The following is a description of a gene set: Human Gene Set: GOBP_GROWTH studied in species Homo sapiens The increase in size or mass of an entire organism, a part of an organism or a cell., and this is the list of marker genes: MATN1, ZNF830, OTOA (NCBI Gene Id 146183), TAF9B, PLEKHA1, TSC22D4, RMI1, FGFR2, STK4, SEMA5B, GLI2, PTCH1, FLRT3, GAS2, ULK2, UBE3A, TAOK2, SH3BP4, EIF4G1, ASPM, CDK1, KPNA1, SOCS2, MYF6, CYP27B1, CDKN1B, GOLGA4, LEPR, EPM2A, FTO, MIR17HG, BMPR2, NRN1L, RBBP6 (RB binding protein 6, ubiquitin ligase), MMP14, HDGFL2, MIR199A1, H3-3B, CDC42, EZR, BLTP1, IL17RB, SGK1, GINS4, MFSD8, AURKA, SPOCK1, RPS6KA3, FGF8, FOXC2, DIO3, COMP, ABL1, PTPN12, HNF1B, WNT3A, RGS2, DVL1, IFT80, GPD2, SOX15, HSF1 (heat shock transcription factor 1), ECM1, BCAR1, GDF2, TTL, GPX4, CYBA, TFRC, IGFBP1, COL27A1, NDRG3, EDN2 (NCBI Gene Id 1907), SPP1, CD81, BBS4, PTPRJ, MIR548C, SGPL1, GALNT3, DDR2, RASGRP2, KDF1, ITSN2, SERPINE2 (serpin family E member 2), BTG1, CHPT1, EZH2, PSRC1, AGT, TSKU, OLFM1, ADCY10, CDK5, IGFBP3, ACVR2B, KMT2D, EMX1 (NCBI Gene Id 2016), G6PD, JADE2 (jade family PHD finger 2), CLSTN1 (calsyntenin 1), CIB1, PPP2R1A, BARHL2, MIR24-1, RNF157, HOXB13, LATS2, ZFPM2, DACT3, SYT17, MLST8, PAX7, PSAP, PLXNA4, WNT10B, AFG3L2, OSGIN2, AGRN, CDKL5, INSR, SOX17, DDX3X, LARGE1, PPP2R3A, NTRK3, PYGO2, SPHK1 (NCBI Gene Id 8877), INO80, CER1, ETNK2, ARHGEF11, KLHL22, ITGB1, BBS2, S1PR1, CDHR2, APOA5, SERP1, ESR2, RACK1, GINS3, SLC1A2, P2RX5, MAPKAP1, AKT1, ALCAM, PSMD10, COBL, SEMA7A, MAP2, MT1B, WT1, WNT2 (NCBI Gene Id 7472), CDA, HSPA1A, PPP1R13L, SLC23A2, XIRP1, LIMK1, WNT3, SOX9, EPHX2, ADRB2, SPAAR, HEY2, RGMA, CD2AP, HSPA1B, NRP2, SMAD1, COL14A1, KLK6, FKRP, HESX1, PAK5, TRPV2, ADM, CRYAB, LAMB2, LIN7A, MIR509-1, LGR6, PIM1, NDRG4, YBX3, MAPT, KIF26B, CACNG7, PPM1F, SFRP2, CHD7, RAI1, WNT7A, GHRL, SMPD3, NDN, GDF15, IGF1 (NCBI Gene Id 3479), PPARD, RSPO2, CAV3, KAT7, SELENON, MYL2, CHRNA1, MAP3K13, BIN3, TOMM70, MIR25, DCSTAMP, ADRA1A, HTRA2, HBEGF, SUPV3L1, SBDS, ACTN3, STRA6, RAD51B, MAEL, ING1, NUBP1 (NUBP iron-sulfur cluster assembly factor 1, cytosolic), ISLR2, PTPN11, RPS6KA1, GH1, FGF20, GNAT2, CCL11, CHEK1, MAPK11, WASF1, CDKN2AIP (CDKN2A interacting protein), ATRN, NTN1, WFS1, BCL2L11, MT1E, ING4, TM4SF4, GHRHR, TMEM38B, PTK6, S100A8, L1CAM, NLGN3, IGF2, NDUFS6, MTOR, TBCE, CTC1, KIAA0319, PALB2, PRSS2, TRIM32, FGF2, PLXNA1, VPS54, POSTN, USP9X, DNM2, SEMA6C, SLITRK6, RPTOR, NCBP1, BMPR1B, PLAG1, POU4F3, EP300, MAG, STC2, PPP1R9B, PAPPA2, NCAPG2, SOX10, BRINP2, HDAC3, SMARCA2, PRLH, SDCBP, GATA3, ITCH, N6AMT1, SLITRK1, CCM2, MIR590, NPR1, EGFR, PRKN, CSNK2A3 (casein kinase 2 alpha 3), ATG16L1, MIR204, ATRX (NCBI Gene Id 6475), PTN, PAK1, ZC3H12D, CHRND, STAT5A, PTGFRN, ROS1, CRK, TNR, PRKAR1A, HRG (histidine rich glycoprotein), CRYAA, SMAD2, PSAPL1, SMAD7, HOXA11, ARMC12 (NCBI Gene Id 221481), RERG, TRPC5, HOXA5, TFCP2L1, BASP1, MYCBP2, MESP1, DDX49, IGFBP7, GLI1, IER3IP1, BRCA2, MT3, PRLR, EREG, FLRT1, EIF4H, PPP3CB, PROX1, MUL1, WWTR1, JADE1, BCL6, LIN7C, COX10, ZFY, MSTN, RIMS2, FXN, CFL1, MED1, APBA1, WFDC1, SORBS2, GAMT, FOXC1, AGTR2 (angiotensin II receptor type 2), YAP1, CEACAM1, SLC6A3, SPAG6, GPX1, EVC, TNFAIP6, MACF1, NIN, SLC4A10 (solute carrier family 4 member 10), PML, SLC12A5, RDH10, DUSP10, PLAC8, CSF1, CD38, MDK, SLC44A4, TMPRSS4, WWC2, TLL2, HEG1, OPA3, MT1G, SLIT2, MMP13, LRP12, RARB, NRN1, PLS1, MT1H, SIX1 (NCBI Gene Id 6495), STC1, FBLN5, ENO1, SMURF1, NPPC, SEMA3F, SLC9A1, DNPH1, DCC, GPR149 (NCBI Gene Id 344758), SPTBN2, CXCL12, TMEM182, NKX6-1, TFAP2C (transcription factor AP-2 gamma), KAT2A, MYMX, BCL2, SPHK2, GNAS, GPR21, ATM, CGRRF1, LTBP4, MYOD1 (NCBI Gene Id 4654), UNC13A, ADPRHL1, C8orf44-SGK3, PAK6, GHR, CCNB1, WNT5A, IST1, MTM1 (myotubularin 1), TEAD1, ST7L, GNG4, RUFY3, FSHR, CGA, SELENOP (NCBI Gene Id 6414), AVP, COA5, FGF1, PRPF19, MIR222, SMARCA4, GRHL2, BCL9, MT1F, CTDP1, EIF4G2, KCNJ8, RIMS1, MT1M, CDKN2C, FKBP8, IGFBP4, VGLL4, PI16 (peptidase inhibitor 16), LAMTOR1, MSX2, INHBA, DMBX1, S100A9, CPNE9, PLCB1, SAV1, EDN1, NPPB, CCNB2, GDF5, ADNP, ZNF639, PHLDA2, ADARB1, SEMA6D (semaphorin 6D), ACACB, SYT3, PPP3CA, H3-5, POC1A, MYH6, SMAD4, HYAL2, ACVR1B, LLGL2, FGF10, CDKN2D, SYT1, TARBP2, MCUB, SPRY1, PPIB, TP73, LHX2, GJE1, SLIT3, PARP2, SKI, MKKS, ENPP1, IL2, FGF7, APP, C9orf72, NINJ1, MT1X, RAB33B, RARG, WDTC1, FSTL4, P3H1, TMEM97, ZFP36L1, OGFR, SESN2, EDNRA, KCNK2, DIPK2A, MIR23A, COL3A1, BNC2, VCL, TGFBR3, TBX2, PRMT2, DRD2, KRAS, SPART, PUM2, TAF8, MAP1B, ATP8A2, NAIF1 (nuclear apoptosis inducing factor 1), APBA2, ATF2, NPPA, B4GALNT2, PKDCC, PTEN, CELA1, PTPRS, ANAPC2, TGFB1, MAPK14, FZD9, NR5A2, TWF2, SEMA4F, ERCC6, VPS13A (vacuolar protein sorting 13 homolog A), XRCC2, ADRB1, EFNA5, MINAR1, MIR195, LGMN, KRT17, TRIM46, LPAR3, SEMA3G, EHMT2, BRINP3, ADIPOR1, ZMPSTE24, LMX1A, SFN, ST8SIA2, CXCL16, TNC, TSPYL2, COL6A1, PELO, EAF2, TGFB2, SFRP1, SALL4, CTTN, SIX3, CYP19A1, CCAR2, PRDM11, ARHGAP4, MELTF, ADAM15, CLIC4, ARIH2, MTPN, PDLIM5, CFLAR, AGR2, PPT1, NRG3, RBP4, PEX5, WNT11 (NCBI Gene Id 7481), GAREM1, TAF10, CDKL3, GPC3, TTC8, NANOS1, LZTS2 (NCBI Gene Id 84445), TMEM108 (transmembrane protein 108), SGK2, CPQ, MT2A, KDM2B, PRKCQ, CREB1, FAM107A, SOD1, MAD2L2, STK11, TMED2, GUCA2B, ADRB3, ZMIZ1, CLASP2, OSGIN1, BAP1, LIN7B, CSNK2A1, RASAL1, CPNE5, DUSP6, GMNC, AVPR1A, URI1, IL7, AAAS, PIK3CA, CD9, SPTBN4, BDNF, RB1, LEP, JARID2, NKX2-5, KLF5, MIR1-1, IQGAP1, CDH4, SRF, FHL1, TBX5, CAMK2D, LGI1, CDK11B (NCBI Gene Id 984), XBP1, PLXNA3, KIF14, BCL11A, PAFAH1B1, F2, ACVR1C, DAG1, ULK1, THBS3, TBL1XR1, SEMA3A, NRP1, TGFBR2, OSTN, GLI3 (GLI family zinc finger 3), RTF1, ODAD3 (outer dynein arm docking complex subunit 3), CPNE1, AR, ESR1, TRIM28, EIF2AK4, NPR2, EXT1, PTK7, CRLF3, EBAG9, SEMA5A, APOE, MEG3, GHSR, SMO, SALL1, AGTR1, PPARA, MEIS1, MAP2K5, CDKN1C, LRP4, RARA, ACSL4 (acyl-CoA synthetase long chain family member 4), WNT7B, TRIM40, NME6, POR, CYFIP1, SERTAD3, NGF, CTNNB1, SYT2, MED12, ZEB2, TSG101, EI24, ARMC10, RTN4, MIR19A, INS, RAPH1, MIR29B1, MBD5 (methyl-CpG binding domain protein 5), ALKBH1, NRG1, KIF26A, STK3, RNF6, GPAT4, FBP1, SERTAD2, COLQ, PTCH2, DCUN1D5, DNAAF3, CDKN2A, GSK3B, AMH, MUSK, IMPACT, SEMA4D, ARID2, EGLN2, SPAG9, VIL1, HNF4A, IHH, SYT14P1, CAPN3, LAMTOR2 (NCBI Gene Id 94954), RYK, LLPH, ALOX15B, EXOSC9 (exosome component 9), KAZALD1, TEC, FOXL2, VPS13B, HYAL1, HMGA2, SIX4, MIR200B, SOX2, SCNN1B, RTN4R, FOXP1, GDI1, DAB2, SPRY2, NOG, CDC73, GATA6, WDR11 (NCBI Gene Id 79207), BRCA1, GDF9, FGFR3, ZPR1, LATS1, ARX, EYS, COPS2, EDN3, HDAC6, SIN3A, SLC39A12, SYT4, RAB21, CCN3, CAPRIN2, POU3F2, PABIR1, PRR5, IFRD1, NEDD4L, HOXD13 (NCBI Gene Id 7859), UBTFL1, DCLK1 (NCBI Gene Id 9201), UCN, MUC12, APOD, NKD1, BDKRB1, MT1A, NLGN4X, PPP2CA, GHRH, COMT, NBN, FGF13, FES, SGK3, ARID5B, TNFRSF12A, EPPK1, RUNX1, CYFIP2, STIL, RAG2 (recombination activating 2), MYOZ1, CCDC85B, JADE3, RASAL2, BCL2L1, BNIPL, CLDN18 (NCBI Gene Id 51208), G6PC1, SH3GL2, GIGYF2, SHH, GATA4, SOS1, NOTCH2, GNAT1, MYOCD, YY1, ITGA4, CLSTN3, ADAM17, EN1, NOTCH1, RBPJ, IL9, TNN, ACVRL1, HLX, CACNA2D2, CRKL, IGFBP5, ERCC2, ASCL3, FLVCR1, CREB3, ATAD3A, FOXO3, SLC25A25, SUV39H1, MEGF8, SPG21 (SPG21 abhydrolase domain containing, maspardin), CEP43, STAT3, TKT, FZD7, SASH3, MEAF6, WDR48, PTX3, KDM5B (NCBI Gene Id 10765), FRZB, FN1, DCUN1D3, ERBB2, TGFBR1, HIF1A, CPNE6, MSX1, HELT, GAREM2, TLE5 (NCBI Gene Id 166), BMPR1A, NINJ2, RXRB, AKAP6, SIPA1, ATF5, MYH10, DCAF13, PRKG1, SLC6A4, TNS2, IP6K2, RGS4, NRCAM, MUSTN1, XPA, PAK4, PHB1, EPB41L5, WRN, WWC1 (WW and C2 domain containing 1), NDEL1, RND2, RICTOR, AKIRIN1, RFTN1, MIR19B1, DCBLD2, GAP43, TMEM196, EXOSC2, H3-3A, EXOSC4, SSNA1, ADAM10, HPN, AUTS2, MIR873 (NCBI Gene Id 100126316), IGFBPL1, BRAT1, TAL2, BLOC1S6, ZFYVE27, STAT5B, MIR208A, DDR1, NIPBL, TP53, VEGFA, ERBB4, POU4F2, MFSD2A, CDH1, ZP3, PLAA, GAS1, ATN1, MYMK, DCAF1, SMAD3, NPM1, PRICKLE1, MEX3C, DRAXIN (dorsal inhibitory axon guidance protein), SLC9A6, SHTN1, GSK3A (NCBI Gene Id 2931), SCGB3A1, RBBP7, EXTL3, TCHP, CRABP2, PDZD11, RC3H2, DIP2B (NCBI Gene Id 57609), NPY1R, AREG, SLIT1, FGF9, DNAJB2, SPG11, PRKCZ, FGFR1, VANGL2, INTS1, EPHA7, BMP10, S100B, FOXS1, BMP4 (NCBI Gene Id 652), SELENOM, STK40, CDK11A, CHST11, NACA (NCBI Gene Id 4666), BST2, ANXA1, PLEC (plectin), ERCC1, DSCAM, DISC1, SLC25A33, TBX20, FOSL2, DERL2, SCAPER, GPAM, NET1, SOCS6, TP53TG5, PLG, GINS1, MIR199B, GJA1, KLF2, TENM4, CTR9, HOPX, MEF2C, LHX1, GJD4, WWC3 (WWC family member 3), DLL1, CISH, ING5, CDKN1A, GRN, SESN1